The following is a description of a gene set: Human Gene Set: MANNO_MIDBRAIN_NEUROTYPES_HRGL2A Cell types are named using anatomical and functional mnemonics prefixed by 'm' or'h' to indicate mouse and human respectively: OMTN, oculomotor and trochlear nucleus; Sert, serotonergic; NbM, medial neuroblast; NbDA, neuroblast dopaminergic; DA0-2, dopaminergic neurons; RN, red nucleus; Gaba1-2, GABAergic neurons; mNbL1-2, lateral neuroblasts; NbML1-5, mediolateral neuroblasts; NProg, neuronal progenitor; Prog, progenitor medial floorplate (FPM), lateral floorplate (FPL), midline (M), basal plate (BP); Rgl1-3, radial glia-like cells; Mgl, microglia; Endo, endothelial cells; Peric, pericytes; Epend, ependymal; OPC, oligodendrocyte precursor cells. species: Homo sapiens from publication La Manno G, Gyllborg D, Codeluppi S, Nishimura K, Salto C, Zeisel A, Borm LE, Stott SRW, Toledo EM, Villaescusa JC, Lönnerberg P, Ryge J, Barker RA, Arenas E, Linnarsson S (PMID 27716510), and this is the list of marker genes: ACTRT3, ALDH6A1, MTTP, KIF1A, TEKT1, CSGALNACT1, PDLIM5, KRT17, SFRP4, PRKCA, LAMB2 (laminin subunit beta 2), FRMPD2, ARMC3, DHCR7, TAGLN2, INSIG1, MOK, IL5RA, GPR155, H2AC6, TMT1A, MPDZ, GJA1, HBG1, SNX31, RIDA, MFGE8, ZBBX, CETN2, GPM6A, CLCN3, MRC2, TMEM47, SH3PXD2B (NCBI Gene Id 57517), EPHA3, SPAG16, CFAP73, ETFRF1, CCL2, H1-2, ADGRB2, TMEM221, PI16, ACSS1, AIF1L, SLC16A9, CHST9, ENKUR, ERF, TRAM2, PREX1, FUT9, ID4, PMP2, DNAAF1, ATP2B2, SMOC1, GPRC5B, H2BC12, MT3, PCDHGB4, ADCYAP1R1 (NCBI Gene Id 117), SPECC1, CFAP144 (NCBI Gene Id 440585), RASSF2, KCNN3, TUBB2B, GOLM1, KCNQ2, SLC11A2, TLE2, PCDH1, CFAP52, ANTXR1, GPC4, SPATA6, SEMA5B, NBEA, INHBB, HBG2, DTX4 (NCBI Gene Id 23220), STON2, MIR9-1HG, MLF1, GULP1, ELOVL2, CRISPLD1, JUN, PDPN, SEMA6A, C12orf76, GALC, DNAJB4, EEPD1, IRX1 (NCBI Gene Id 79192), FNDC3B, NOTCH2, SELENOP, TCF4, SEC11C, PPP2R2B, COLQ, SOX6, GABBR2, INPPL1, PARD3B, P3H4, WLS, TTC29, VCAM1, MCTP1, SEZ6L, CNMD, C2orf72, DNAAF3, PLCD3, KCNMB1, SERPINE2, ANOS1, ABCA5, DNAJB1, PCDH7, CSPG5, NKAIN4, CDR1, PDE1A, CD44, METRN, SOX21, ROPN1L, CFAP299, KCNK1, WWC1, NDRG2, OR11H2, ERMARD, IQCG, DCLK2, TTYH3, HBA2, CLU, JAG1, AASS, ITPR2, REST, DLEC1, BCAP29, MKX, AHNAK, PDE1C, SYPL1, HEPACAM, IQGAP2, SERPINH1, NPC2, SORCS2, YBX3 (Y-box binding protein 3), PACRG, IRX4, C8orf48, MFAP4, LFNG, PALS1, LIPA, HAPLN3, PER1, RSPH1, TAFA5, KLF15, COL11A1, KIRREL3, HMGCS1, SORBS1, ELN, HES4, SPRY1, PLP1, DNALI1, NCAN, CAST, BDH2, CYP26B1, TMEM231, ILDR2, ALDH9A1 (NCBI Gene Id 223), SOX8, ZMAT1, HEATR5A (NCBI Gene Id 387979), CCDC146, ALDOC, PPT1, SPAG1, NFIX, SOX2, FADS2, LRP1, HSDL2, LRRC17, OBSL1, COMT, MXRA8, DNAAF4-CCPG1, ITGB5, CXCL2, PDZRN3, AQP4, CFAP47, CEP126 (centrosomal protein 126), TMEM18 (NCBI Gene Id 129787), SCN1A, TOM1L2, ABHD2, CXCR4, ITM2C (NCBI Gene Id 9523), HES5, CLXN, SNORA77, B3GAT1, EZR, PSAT1, EDNRB, ADAMTSL4-AS1, MAMDC2, HTRA1, ARHGEF1, SLC1A3, LTA4H, HSPA7, FZD2, CIMAP3, TNFRSF11B, DCLK1, SLITRK2 (NCBI Gene Id 84631), SLC15A2 (solute carrier family 15 member 2), CCND2-AS1, NDNF, MAGT1, PLTP, LMCD1, IGSF5, TRIL, KIF9, PON2, TSPAN18, RSPH4A, ATP13A4, VSTM2L, PSAP, SESN3, SFRP1, TSC22D4, FAM3C, RANBP3L, HSPA6, HSPB8, CFAP44, PXDC1, RAB6B, DIO3, MMD2, ATXN1, RAB9A, GAREM2, MORN2, DNAH7, LRRN3, UBL3, ITGAV, NDP, ENPP2, LPCAT1, CFAP45, CRYM, IFI27L2, PTPRZ1 (NCBI Gene Id 7983), FABP7, NLGN1, NLGN4X, VEPH1, TPPP, UBXN1, NTRK3, SCAMP2, WNT7A, CACNB2, ZFP36L2, SCG3, GLIS3, CMTM5, PMP22, MFRP (NCBI Gene Id 83552), EFEMP1, CD81, CPNE2, TSPAN7, CAP2, EFHC2, CCDC175, EGFR, PCSK6, GRM3, FAM216B, KLHDC8A, GATM, CTNND2, SLC25A18, ABAT, SLC39A12, NPAS3, LPIN2, DENND2B, PALLD, NEK11, AFF2, WSCD1, FLRT3 (fibronectin leucine rich transmembrane protein 3), CPNE5, FOS, ANXA5, FAM181B, NLGN4Y, STOM, GPC1, DPP6, RAB27A, C12orf75, ADAM33, BCAN, CCDC39 (NCBI Gene Id 339829), KAT2B, WDR38, DHX32, LRRN2, HAS2, EMP1, AKAP6, ASTN1, IER2, RGMA, TTYH1, MIR99AHG, DNAH6, HEPN1, KCTD12, OAT, TC2N, CFAP210, DOK5, EPHB1, CHST3, KCTD21, CFAP126, FAT2, KBTBD11 (kelch repeat and BTB domain containing 11), PEA15, INTU, ZNF474, BMP7, C6orf118, SNORA12, CFAP107, SLC4A4, FAM66D, TIMP3, FOXJ1, SCD, FLNC, CRB1, NMNAT2 (NCBI Gene Id 23057), KCNE5, HDAC4, PLIN3 (NCBI Gene Id 10226), NCKAP5, FHL1, PTK2B, SPEF1, SCRG1, LITAF, ADIRF, SOX1, SLC7A11, DBX2, NRXN1, CSMD3, LRRK2, PPIL6, FGFR3, LIX1L, PHGDH, FAM167A-AS1, MYORG (NCBI Gene Id 57462), IRX2, GNG12, GNG7, EPB41L4B, KRT14, LGALS3BP, RGS2, VWA3A (von Willebrand factor A domain containing 3A), APC, LAMA4, NACC2, CYP2F1, TCIM, THOC2, PRCP, LRP2, CIBAR2, MASP1, RFX4, COL27A1, CNN2, KRT5, ANXA6, MSMO1, PRDM8, BCHE, SEL1L3, ITGB8 (NCBI Gene Id 3696), LTBP1, MORN5, OPHN1, SPRY2, ARHGEF4, RPGR, KCNJ1, PLPP3, STK33, LIPG, NRARP, EGR1, GPM6B, PLXNB1, CCN2, ADGRB3, RRAGD, RIPOR2, SHISA3 (NCBI Gene Id 152573), NTRK2, TGIF2, LIX1, ARAP2, LRRIQ1, SPMIP6, LLGL1, PI15, DDAH1 (dimethylarginine dimethylaminohydrolase 1), AK4, NCAM2, OSBPL6, SLC1A2, LZTFL1, TNC, LYPD1, MGST1, MCC, HOATZ, GLUD1, PBXIP1 (PBX homeobox interacting protein 1), TGFB2-OT1, DNAI2, C8orf34, SPRED1, FGF1, RPS27L, GFAP, WIPF2, THSD4, ATP1B2, XYLT1, SPARCL1, EFEMP2, GRIA1, FSTL5, COL8A1, HYDIN, GASK1B, DTNA, RASSF4, LIMCH1, SOX9, DAG1, LRRC4C, CCN1, CDC42EP4, SLC1A4, B3GNT2, CCDC17 (NCBI Gene Id 149483), QKI, EVI5, SPAG17, PRKAA2, LDLRAD4, ZNF497, LRATD2, FABP5, VIM, CREB5, NSMF, FOSB, CELSR1, NME5, KLHL25, NHERF1, ARHGEF6, CADM4, SFRP2, CDH13, TMED5, GDPD2, S1PR1, TMEM161B-DT, TMEM98, ZFP36L1, P4HA1, NELL2, CHST6, FAT3, ATP1A2, FGFBP3, SCN4B, TSPAN6, HBA1, CARINH, TF, CST3, NFIA, DCDC1, DKK3, DNAI4, EGR2, CFAP77, SNCAIP, BOC, DYNLT5 (NCBI Gene Id 200132), HES1, FAT1 (NCBI Gene Id 2195), ATP2B4, TMEM232, NLGN3, CFAP90, RFTN2, MNS1, SCHIP1, MLC1, MCL1, IGDCC3, LPAR4, NRK, ARVCF, ENHO, C1orf21 (chromosome 1 open reading frame 21), DNAJB13, GCA, HSPB1, ROBO3, FOLH1B, PAG1, COL4A5, F3, PDLIM3, MPC1, CDHR1, CPXM2, PTCH1, PHLPP1, PHYHIPL, KCNIP1, LRIG1, SLIT1, TIMP4, GPR137B, IFI44L, SLC13A5, WEE2-AS1, ADGRG1, NFIB, CA12, MAML2, SLC6A9, SALL2 (NCBI Gene Id 6297), ICA1L, SMYD3, SALL1, CRB2, KLHL32, TP53TG1, CRYAB, NEK6, GRID2, IGFBP2, TMEM9B, ODAD1, SOX2-OT, NADK2, NOTCH1, IQCA1, LIFR, SRGAP3, ARHGEF26